The following is a description of a gene set: The extension of an RNA molecule after transcription initiation and promoter clearance at a DNA-dependent RNA polymerase promoter by the addition of ribonucleotides catalyzed by an RNA polymerase. studied in species Homo sapiens Human Gene Set: GOBP_DNA_TEMPLATED_TRANSCRIPTION_ELONGATION, and this is the list of marker genes: INTS2, SCAF8, INTS8, INTS1 (integrator complex subunit 1), TEFM, CDK9, CTNNB1, SART3, PCID2, INTS7, SUPT4H1, CCNT1, MED22, INTS11, MED6, MED27, CDC73, TOX4, NELFE, ZNF326, POLR2M, ELOA2, INTS14, MED9, CDK13, INTS13, CCNK, PWWP2B, TCERG1, TCEA3, PAF1, INTS10, INTS5, IWS1, SOX10, CTR9, PBRM1, RECQL5, INTS9, MAP2K1, GTF2F2, INTS6, HNRNPU, MED8, MED14, SUPT16H, MED1, USP15, WDR82, INTS4, ZMYND11, MED25, TCEA2, MED18, SIRT6, ZMYND8, MED26, ERCC6, RNF168, NELFCD, EPOP, RN7SK (RNA component of 7SK nuclear ribonucleoprotein), CCAR2, SETD2, POLR1F, WDR43, EAPP, LARP7, MED31, LEO1, SKIC8, EZH2, RNF8, MED24, BTBD18, ELL3, LDB1, NELFB, MED4, MED28, SUPT5H, MED7, PPP1CA, MED10, TCEA1, MED17, MED16, ELOF1, SHH, MED20, ELP2, MED21 (mediator complex subunit 21), MED30, CCNT2, AXIN1, GTF2H5, PARP1, EAF2, INTS3, NCBP1, ELOB, ADRM1, TSFM, MED15, POLR2I, NCBP2, ELOA, POLR2E, EAF1, PWWP2A, CTDP1, GLYR1, MED29, MED11, INTS12, CDK12, ZC3H4, SUPT6H, HMGN1, VHL, SETD5, PPP1R10, ERCC2, ELL, NELFA, MED23, ERCC3, RTF1, GTF2F1, HEXIM1, ENY2, POLR1D, BRD4, POLR1E, KAT7, MED19, ELL2